The following is a description of a gene set: studied in species Homo sapiens Bleeding with minor or no trauma Human Gene Set: HP_BLEEDING_WITH_MINOR_OR_NO_TRAUMA Significant bleeding or hemorrhage without significant precipitating factor., and this is the list of marker genes: SLC37A4, KRT1, F13A1, MCFD2, F13B, EPHB2, F8, LMAN1 (lectin, mannose binding 1)